The following is a description of a gene set: Marker genes curated from the annotated cluster as represented in the Descartes Human Gene Expression During Development database. from publication Cao J, O'Day DR, Pliner HA, Kingsley PD, Deng M, Daza RM, Zager MA, Aldinger KA, Blecher-Gonen R, Zhang F, Spielmann M, Palis J, Doherty D, Steemers FJ, Glass IA, Trapnell C, Shendure J (PMID 33184181) Human Gene Set: DESCARTES_FETAL_PANCREAS_ISLET_ENDOCRINE_CELLS The gene expression program underlying the specification of human cell types is of fundamental interest. The study authors generated human cell atlases of gene expression and chromatin accessibility in fetal tissues. For gene expression, the study authors applied three-level combinatorial indexing to >110 samples representing 15 organs, ultimately profiling ~4 million single cells. The study authors leveraged the literature and other atlases to identify and annotate hundreds of cell types and subtypes, both within and across tissues. Our analyses focused on organ-specific specializations of broadly distributed cell types (such as blood, endothelial, and epithelial), sites of fetal erythropoiesis (which notably included the adrenal gland), and integration with mouse developmental atlases (such as conserved specification of blood cells). These data represent a rich resource for the exploration of in vivo human gene expression in diverse tissues and cell types. species: Homo sapiens, and this is the list of marker genes: PCSK1, IAPP (islet amyloid polypeptide), GRM4 (glutamate metabotropic receptor 4), LINC02131, SLC17A6 (NCBI Gene Id 57084), MLXIPL, SLC26A4-AS1, MAFA, SST, RAB26 (NCBI Gene Id 25837), GLRA3, AMN, QPCT, RGS7, CEP126, SMIM32, MAB21L4, KCNH6, TTR, GIPR, FEV, GJD2, ENSG00000229797, CRYBA2, PTPRN2, ASIC2 (NCBI Gene Id 729787), KCNMA1, TSPAN1, GRIA3, NOL4, ADGRA1, BTBD17, NOL4L-DT, TRPC7-AS1, NR0B1 (nuclear receptor subfamily 0 group B member 1), MS4A8, UCN3, ST6GALNAC5, GPC5-AS1, CROCC2, STXBP5L, CDC42EP3-AS1, ELFN2 (extracellular leucine rich repeat and fibronectin type III domain containing 2), SYNDIG1L, VWA5B2, NAMA, KCNMB2, SCGB2A1, GAD2, SLC22A14, LINC01548, LINC01014, LINC01885, TMEM190, EYA2, TMEM61, TUNAR, ISL1, DEUP1, RIPPLY3, NKX2-2, ENSG00000263571 (novel transcript), RFX6, SLC35F4, ENSG00000259881, PPP1R1A, ABCC8, HISLA, RN7SL164P, ECEL1, CACNA1A, SLC6A4, PAX6, PPP1R14C, LINC01195, GCG, C1orf127, NEUROG3, DCDC1, TMPRSS6, MAN1A2P1, SHISAL2B, EDN3, PCSK2, ENSG00000253726, MINDY2-DT, LINC00616, PHGR1, MUC5B, KCNJ6, NEUROD2, DUSP9, GRHL3, CRH, LINC01484, FFAR4, ELAPOR1, G6PC2, HTR1F, HEPACAM2, ASB9, GCK, LINC02197, PLPPR1, SLC45A2, EPHA8, INS-IGF2, NECAB2, PROC, FAM135B, NEUROD1, CHRND, ENSG00000271860, PAX4, ARX, ISX, CALCR, CHGA, KCNJ3, HADH, ENSG00000239572, LINC01586, NKX2-2-AS1, GHRL, DNAH5, CLTRN, KCNK16, ACVR1C, LINC00907, SERPINA10, HHATL, LINC01574, IGFBPL1, KLK12, MYREM, GPR158, INS, LINC01886, LHX4, SERTAD4BP, RPL36P6, ENO1P1, TPD52, TTC39A-AS1, IRX2-DT, NKX6-3, DDC, CLDN18, CNGA3, CERKL, RGS4 (regulator of G protein signaling 4), SYNGR4, KLHL32, TRPM5, PYY, SSTR5-AS1, PLCXD3, LINC01976, GPD1, ERO1B, SLC30A8, MIR7-3HG (NCBI Gene Id 284424), FTCD, IRX2, EGR4, CIBAR2 (NCBI Gene Id 339145), RBP4, BAIAP3, GJD2-DT, C22orf42, PTPRN, ST18, PPY